The following is a description of a gene set: The evagination of the Golgi membrane, resulting in formation of a vesicle. species: Homo sapiens Human Gene Set: GOBP_GOLGI_VESICLE_BUDDING, and this is the list of marker genes: ARFGAP3, GBF1, GOLPH3, MYO18A, TMED9, PRKCI, TMED2, TMED10, ARFGAP2, GOLPH3L